The following is a description of a gene set: from publication Chen Y, Wang X (PMID 31504780) Human Gene Set: MIR4440 species: Homo sapiens Genes predicted to be targets of miRBase v22 microRNA hsa-miR-4440 in miRDB v6.0 with MirTarget v4 prediction scores > 80 (high confidence targets)., and this is the list of marker genes: GSK3B, RP1, CLDN8, ZNF830, APOD